The following is a description of a gene set: Serotonin receptor 2 and ELK-SRF/GATA4 signaling Human Gene Set: WP_SEROTONIN_RECEPTOR_2_AND_ELKSRFGATA4_SIGNALING studied in species Homo sapiens, and this is the list of marker genes: MAPK1, NRAS, MAP2K1, GNAQ, MAPKAPK2, RAF1, RASGRF1, HRAS, RASGRP1, SRF, ITPR1, ELK4, HTR2C (NCBI Gene Id 3358), MAP2K2, ELK1, HTR2B, HTR2A, MAPK3, GATA4, KRAS